The following is a description of a gene set: studied in species Homo sapiens Human Gene Set: HP_ABNORMAL_JUDGMENT Beliefs that deviate from what is considered rational or within the range of normal human judgment and belief formation. Abnormal judgment, and this is the list of marker genes: GPR101, SETD5, PHIP, HIVEP2, CBS, CACNA1H (calcium voltage-gated channel subunit alpha1 H), H1-4, IMPDH2, SERPINA1, DEAF1, NAA60 (NCBI Gene Id 79903), MAPK1, PLA2G6, PLCH1, PQBP1, KMT2E, LZTFL1, GBA1, EIF2AK1, BBS7, AR, TGFBR2, HECTD4, YY1, EBF3, CEACAM6, TMEM106B, WAC, STX1A, PRKAR1A, DLAT, MBD5, MEN1, TSC1, GABBR2, NONO, GNA11, CHD8, TMEM147, TMCO1, PHF21A, HNRNPH2, STEEP1 (STING1 ER exit protein 1), FGF13, NKX2-1, DAOA, TAF15, PMS2, PPM1D, NSD2, RET, FTSJ1, BBS2, CDH23, SETBP1, CTNNB1, DEPDC5, CHD7, TAF1, NHLH2, SOD1, PDZD7, RIMS2, ALDH4A1, SDHB, CDKN2A, DLST, SCN1B, MT-TW, BCL11B, TLK2, SCN1A, COQ2, UQCRC1, SRCAP, TANC2, SIX3, TNFSF4, MED12L, CLRN1, SYN2, VPS37D, EDNRA, NEXMIF, BMPR1A, SNRPN, SDHD, ERBB4 (erb-b2 receptor tyrosine kinase 4), CRIPTO, KISS1R, SYNJ1, TBK1, TTR, MAPT, ASH1L, SRRM2, KCNN2, CHRNB2, SYT1, PRRT2, BBS5, PDGFRB, POLG, PRR12, CREBBP, LRRK2, HTRA1, VPS13C, KRAS, KMT2B, DENND5A, FOXP1, GCH1, OTC, TGIF1, WDR45, POGZ, CHEK2, NFIX, BBS4, POLD1, STX1B (syntaxin 1B), PPP2R2B, CEACAM3, EP300, PINK1, THRB, PARK7, STAG2, APC2 (NCBI Gene Id 10297), NIPBL, SETD1A, NEK1, MT-CO1, MT-CO3 (mitochondrially encoded cytochrome c oxidase III), AHDC1, SPRY4, UBQLN2, ADNP, TTC8, UNC13A, SCN9A, LGI3 (leucine rich repeat LGI family member 3), TSC2, MOG, MT-TF, HSPG2, TLR7, ZNRF3, EPCAM, HTRA2, ARSG, CAPRIN1, MYO7A, MT-TL1, SHH, PDE10A, POLE, ZIC2, SLC25A13, OPTN, SDHA, HMOX1, BUD23, PMS1, FMO3, ANXA11, UCHL1, PRKN, RFX7, DNMT3A, SCN2A, FRMD5, HCRT, SCAPER, SLC26A9, CLTRN, TET3, EIF4H, HEXB, NEFH, JRK, NR4A2, IFT27, ATM, SOX5, ATRX, CACNA1A, BRD4, IGF1R, FA2H, VPS13A, RRM2B, SETD1B, CFAP418, BBS10, SATB2, GNB1, CTCF, CEP19, WFS1, PFN1, TWNK, SLC6A14, GTF2IRD2 (GTF2I repeat domain containing 2), KIF1B, MLXIPL, CIC, DRD3, RAI1, ARID2, PPP1CB, STUB1, RNF125, ATXN2 (ataxin 2), CLCN3, TREX1, CHRNA4, MT-TS2, DPH1, CCNF, EHMT1, GABRD, THOC2, MKKS, RPS20, CLIP2, TARDBP, HFE, DAO, GLT8D1, SPART, GNRHR, PSMD12, GTF2IRD1, C9orf72, TAC3, TBL2, GABRG2, SDHC (succinate dehydrogenase complex subunit C), MATR3, SEMA4A, CRH, KMT2A, FGFR1, AGO1, TRANK1, SLC35C1, GRIN2A, SMC1A, EPAS1, NFASC, HS6ST1, RTN4R, CFAP410, SDCCAG8, GRIK2, SLC45A1, PCDH15, GTF2I, BPTF, FLII, MLH1 (mutL homolog 1), NCF1, CHMP2B, TYROBP, DISP1, MSH6, USH2A, MIR17HG, NSD1, FGF8, CHCHD10, NDP, KCNT1, GLI2, DUSP6, IFT74, GSTM3, CEP290, MT-ND4, TRIM32 (tripartite motif containing 32), CHI3L1, SLITRK2, ZBTB20, SGCE, MT-TQ, STX16, SLC2A1, DNAJC6, CDKL5, FH, ZFX, MIF, TBP, DYRK1A (NCBI Gene Id 1859), DCTN1, ADGRV1, APOL2, NPHP1, SLC11A1, CLN3, MAN2B1, MAMLD1, SNCB, PDE11A, KCNN4, SLC4A10 (NCBI Gene Id 57282), TERT, PTRHD1, WHRN, VCP, APOL4, UFD1, SLC6A19, HCN1, SHQ1 (NCBI Gene Id 55164), PON3, LIMK1, FOXH1 (forkhead box H1), MTHFR, COMT, PRKAR1B, USH1G, USP48 (ubiquitin specific peptidase 48), MT-ND5 (mitochondrially encoded NADH:ubiquinone oxidoreductase core subunit 5), MKS1, ASCC3, HLA-DQA1, MSH2, MT-ND1, COL7A1, BBS12, PDGFB, ABCC9, SEC24C, HLA-DQB1, CDC42BPB, GM2A, RNU4-2, PSAP, NF1, ALAD, DPH2, DDB1, ANG, MEFV, DCTN4, GP1BB, BAZ1B, NR3C1, DLL1, ALG14, PTPA, TOR1A, NAGS, BBS1, MUTYH, EIF2B1, EMC10 (ER membrane protein complex subunit 10), GRN, CPOX, CIZ1, CDON (cell adhesion associated, oncogene regulated), MMP1, SETD2, DRD2, HDAC8, MAX, PON1, FKBP6, POLG2, P2RY11, KISS1, MDH2, MT-CO2, HTR2A, GABRA1, PRNP, PRPH, USP8, GLA, PON2, CCND1, PSEN1, NSMF, HARS1, CSF1R, NTNG1, MT-TH, MSTO1, BBS9, FXN (NCBI Gene Id 2395), SRPX2, IFNG, UBAP2L, MT-ND6, TBX1, SIN3A, CABP4, PURA, SMC5, ESPN, AIP, PPARGC1A, JPH3, TRIP12, CIB2, SMC3, ZNF365, SNCA, HNRNPA1 (NCBI Gene Id 780920), BRAF, KPTN, FUS, RAD21, SLC2A3, HIRA, SQSTM1, NOTCH3, FMR1, RREB1, SPECC1L, WDPCP, RLIM, PTCH1, GAS1, VHL, RFC2, PIK3CA, XK, CFTR, METTL27, PAH, USH1C, CTSH, KCTD17, TCF12, VAPB, GNRH1, GCLC, PAK3, NODAL, JMJD1C, HLA-DRB1, EFHC1, IQSEC2, SLC25A4, STIL, SLC7A6OS, AP1G1, SLC6A4, YWHAG, GABRB3, ARSA, ARL6, TACR3 (NCBI Gene Id 6870), ATP1A3, PPOX, TREM2, CYP27A1, GNAS, FIG4, GALT, SCLT1, ACSL4, TMEM270, TP53, PCDH19, SDHAF2, PODXL, MECP2, CASR, BBIP1, HMBS, SPTBN1, TMEM127, SLC9A3, MYT1L, CLCN4, GLE1, ELN (elastin), HTT, PROK2 (prokineticin 2), CDH2, LARP7, KANSL1, ALDH5A1, CLCA4, CEP78, TCF20, ADCY5, TGFB1, BRCA2, IFT172 (NCBI Gene Id 26160), FGF17, SLC25A11, NFIB, TAF6, OCRL, TTC19, FLT4, DNAJC30, CHRNA2, ATP7B, WDR11, PROKR2, ARVCF, WARS2